The following is a description of a gene set: Abstract: Trastuzumab-induced cardiotoxicity (TIC) is a common and serious disease with abnormal cardiac function. Accumulating evidence has indicated certain non-coding RNAs (ncRNAs), functioning as competing endogenous RNAs (ceRNAs), impacting the progression of cardiovascular diseases. Nonetheless, the specific involvement of ncRNA-mediated ceRNA regulatory mechanisms in TIC remains elusive. The present research aims to comprehensively investigate changes in the expressions of all ncRNA using whole-transcriptome RNA sequencing. The sequencing analysis unveiled significant dysregulation, identifying a total of 43 circular RNAs (circRNAs), 270 long noncoding RNAs (lncRNAs), 12 microRNAs (miRNAs), and 4131 mRNAs in trastuzumab-treated mouse hearts. Subsequently, circRNA-based ceRNA networks consisting of 82 nodes and 91 edges, as well as lncRNA-based ceRNA networks comprising 111 nodes and 112 edges, were constructed. Using the CytoNCA plugin, pivotal genes - miR-31-5p and miR-644-5p - were identified within these networks, exhibiting potential relevance in TIC treatment. Additionally, KEGG and GO analyses were conducted to explore the functional pathways associated with the genes within the ceRNA networks. The outcomes of the predicted ceRNAs and bioinformatics analyses elucidated the plausible involvement of ncRNAs in TIC pathogenesis. This insight contributes to a better understanding of underlying mechanisms and aids in identifying promising targets for effective prevention and treatment strategies. studied in species Mus musculus Mouse Gene Set: XIE_TRASTUZUMAB_CARDIOTOXICITY_CIRCRNA_GENES from publication Xie S, Zhou N, Su N, Xiao Z, Wei S, Yang Y, Liu J, Li W, Zhang B (PMID 38577019) Host genes for 43 circRNAs that were found to be significantly dysregulated in the trastuzumab-induced cardiotoxicity (TIC) model, and this is the list of marker genes: Ppip5k1, Mtus1, Gsap, Cnksr3, Fam135a, Atrnl1, Vwa8, Mpzl1, Cnot6l, Ttn, Syne2, Snx29, Pecam1, Picalm, R3hcc1l, Vdac2, Slc35f5 (NCBI Gene Id 98413), Vmp1, Pan3, Wdr1, Wwc2, Evl, Btaf1, Crim1, Akap6, Ppfia1, Oxct1, Aftph, Ank2, Dpysl2, Mlip, Dcun1d4, Ash1l, Rftn1, Snx9, Blvra, Cdk13, Atad2b, Cluh, Tbcel